The following is a description of a gene set: The gene expression program underlying the specification of human cell types is of fundamental interest. The study authors generated human cell atlases of gene expression and chromatin accessibility in fetal tissues. For gene expression, the study authors applied three-level combinatorial indexing to >110 samples representing 15 organs, ultimately profiling ~4 million single cells. The study authors leveraged the literature and other atlases to identify and annotate hundreds of cell types and subtypes, both within and across tissues. Our analyses focused on organ-specific specializations of broadly distributed cell types (such as blood, endothelial, and epithelial), sites of fetal erythropoiesis (which notably included the adrenal gland), and integration with mouse developmental atlases (such as conserved specification of blood cells). These data represent a rich resource for the exploration of in vivo human gene expression in diverse tissues and cell types. Human Gene Set: DESCARTES_FETAL_KIDNEY_URETERIC_BUD_CELLS species: Homo sapiens from publication Cao J, O'Day DR, Pliner HA, Kingsley PD, Deng M, Daza RM, Zager MA, Aldinger KA, Blecher-Gonen R, Zhang F, Spielmann M, Palis J, Doherty D, Steemers FJ, Glass IA, Trapnell C, Shendure J (PMID 33184181) Marker genes curated from the annotated cluster as represented in the Descartes Human Gene Expression During Development database., and this is the list of marker genes: KRT7, VTCN1, LINC01170, DUOXA1, MMP7, FA2H, CYP4F11, EVPLL (envoplakin like), ERP27, SPINK1, EVPL, PERP, SLC52A3, GRHL2-DT, VWA5B1, SCNN1G, LY6K, CAPNS2, CPXM2, LINC02778, PIK3C2G, BOLL, ACSM6, MOGAT3, GCNT4, MYH14, WNT7B, TTC6, CYP4B1, ALDH3B2, GPX2, POF1B, KRT15 (keratin 15), AOC1, TFAP2A, SIGLEC15, AQP2, PRR35, DIRAS2, SDC1, COBLL1, TMEM125, SHROOM1, CWH43, PTGER1 (NCBI Gene Id 5731), RHBG (NCBI Gene Id 57127), LINC02894, LINC00511, EMX1, MYEOV, NUDT16-DT, KCNS3, SPMIP8, MIR200C, CCDC9B, ARHGEF38, CYP2J2, KSR2, LDHD, ENSG00000254951, OVOL1, MIR31HG, LEP, GPC1-AS1, ALDH1A1, MAB21L4 (mab-21 like 4), TMEM238L, CLDN7, ANKRD34B, MFSD6L, ATP10B, RNF223, FXYD3, DHRS2, S100P, ADIRF, PRDM16, BCAS1 (brain enriched myelin associated protein 1), CGN, SPRR1A, MUC15, PDE7B, TMC4, RAB11FIP2, HPGD, FAM181B, ENSG00000259704, PLEKHN1, PKP3, MUC1, PLS3-AS1, AGAP11, ITGB4, SYT16 (synaptotagmin 16), LAD1, VSIG2, TFAP2C, IQANK1, CTXND1, ESRP1, HSPD1P6, GJB4, ENSG00000269155, CCNO, NECTIN4-AS1, ENSG00000250685, BNIPL, RAB17 (RAB17, member RAS oncogene family), IL1RAPL2, ELF3, ANXA3, UPK3A, GJB3, GALNT12, SLC38A4, FMO9P, TMEM184A, KRT5, WNT9B, RAB17-DT, VGLL1, PLA2G2F, CBLC, TMEM45B, MAP3K21, CLIC6, BSPRY, RASEF, RDH10-AS1, KRT23, LYPD6B, CAPN13, MLPH, ST14, S100A14, FAM110C, LINC00051, KRT80, EPB41L4B, RDH10, MAL2, MAOA, CCNO-DT, B3GNT3, GRHL1, GJB6, PLEKHG6, FAM131C, RNF207-AS1, COSMOC, SAMD12, ENSG00000225144, PRR15, RNF183, MIR200B, COL17A1, NECTIN4, EPN3, ADGRF1, SSH3, SNTG1, MYO3B-AS1, GPR15LG, ENSG00000258471, ODAM, FAM3D, PRSS22, SSTR5, C6orf132 (NCBI Gene Id 652183), CYP4Z2P, TFAP2A-AS1, SNCG, CFI, ENSG00000243004, CXCL17, ARHGEF38-IT1, ACER2, CIMIP2C, RPL21P72, ADH1C, SNX31, MACC1, CYP24A1, SCIN, ENSG00000267288, SYT8, C4orf19, TACSTD2, LINC02944, TRIM29, PROM2, SPTLC3, S100A2, ENSG00000259039, FBP1, SLC38A11, GRHL3, TSPAN1, PSCA, L1CAM, RET, UGT1A1, CALB1, SDK1, ELF5, PAK6, PM20D1, MGC32805, LINC01139, DEGS2 (NCBI Gene Id 123099), KRT20, FER1L4, SMIM6, PPFIBP2, PLA2G4F, CNGA1, NIPAL4, PPL, SPINT1, PVALB, AVPR1A, MYO3B, UPK1A, FAM83B, DCAF12L1, ELMO3 (engulfment and cell motility 3), SLC9A4, ENSG00000265246, ARL14, SCNN1B, SLC30A2, ACOXL, CFAP157, TRPV6 (transient receptor potential cation channel subfamily V member 6), CDCP1, RNF43, COLCA1 (colorectal cancer associated 1), POU5F1, CLPSL1, LINC00645, LCN12, FAM3B, ATP12A, AKR1C2, SPR, LINC02888, TNS4, TAC3, SEPTIN9-DT, EHF, PRDM16-DT, UGT1A6, LINC02343, MUC6, KCTD8, RBBP8NL, GOLT1A, IRF6, LY6D, KRT8, KRT18, CLDN4, SMIM22, EDN2, GGT6, SLC9A2, CLDN8, FOXQ1, ITGB6, MIR200CHG, UPK1B, MIR205HG, HMGCS2, FOXA1, KRT19, BICDL2, SHH, CYP4F3, SPRR3, RNF128, RASSF6, PKP1, ESRP2, GRHL2, GATA3-AS1 (GATA3 antisense RNA 1), FRK, LEAP2, PSORS1C3, AARD, TMPRSS2, OVCH2, UPK2 (uroplakin 2), LAMB3, IVL, NIPAL1, FSTL4, PTK6, WNT6, ERVE-1, TMEM30B, HR, ENSG00000257989, MSX2, POU3F4, TTC39A